Given this list of marker genes GPRC5B, OPA1, CDH16, GPR107, NLRP2, SLAMF8, BICD1, CTSW, F11R, MYL3, GOLM1, BTN3A1, DACH1, MAN1C1 (mannosidase alpha class 1C member 1), MYH6, ANGPTL7, TGFBR3, POLR1F, RORA, SLC2A6, GGPS1, BCL2L14, METTL3, PVT1, C2CD3, CHRNA2, ATP2A2, RIN3, VPS52, MTMR11, ASCL3, LTK, ACADSB (acyl-CoA dehydrogenase short/branched chain), SFTPB, LRRC37A3, PREX2, KDM4B, POLR3F (NCBI Gene Id 115527), VPS13B, PAK6, FSCN3, ZMYM6, PRND, SOX11, SLC7A1, ARHGEF15, HECTD3, PGBD5, PEPD, SSBP1, TNFAIP2, ADARB2 (NCBI Gene Id 55523), MET, MRPL34, EOGT, CDADC1, SLC17A4, PRRC2C, SMIM14, KLRC3, RNF220, APOC1, PLEKHA1, KTN1, RSAD1, LRIG2, CEACAM7, SLC7A2, OVGP1, SLC35D2, UMPS, NELL2, UTS2, NR3C2, ALOX15B, TARS2, ACSF2, GPR171, RANBP17, THSD7A, ZBTB44 (NCBI Gene Id 29068), DAZL, FHIT, MARCHF1, SLC35F6, EFR3B, KPTN, PSMC3IP, TPSG1, MOGAT2, NAB2, MYOM1, APOC2, CARF, GID4, AP3M2, GJC1, CCZ1B, LIG3 (DNA ligase 3), GFAP, GEM, CRHR2, PRKAA1, CYP21A2, SBNO1, SERPINA7, PAK3, SLIT2, IKZF3, KRT5, SETD6, FBXW11, SDR39U1, TSPYL2, WWC1, MARS1, ATP1B1, RAD17, KLHL35, HEATR6, LRRC37A4P, C3, CCDC92, FHL5, SLC35A2, ACSBG2, CYB5R3, ENSG00000274253, TPM3 (NCBI Gene Id 91191), HOXD11, MMS19, NSD3, NPY6R, PORCN, EMP1, CHRNA1, ABTB2, H4C9, BRWD1 (bromodomain and WD repeat domain containing 1), SPRR2B, DHRS3, AKR1C3, RTCA, BMERB1, STMN2, SPATA2, RAPGEFL1, FSTL1, BIN1, KRIT1, GADD45G, LY6G6D, NME5, BFSP2, MATCAP2, EXOSC2, PALM, EDA2R, KCNMB1, SIDT2, TASOR, CLIP3, OR6A2, TMEM39A, FCRL2, CKB (NCBI Gene Id 96634), GNG12, CHST3, LINC00342, RFX5, NEB, BAIAP3, PGF, ELF3, SLC49A3, NCAM2, CAT, GPR182, RER1, IL18, PCGF1, TAF5L, CLCA3P, ADAMDEC1, PHTF2, NFAT5, ABCF2, JPH3, PLAC1, TCP10L3, APOD, RAB3A, SYT2, IFT46, GSK3A, ZAP70, here is a description of the gene set: Genes up-regulated in HEK293 cells at 6h after stimulation by muramyl dipeptide: over-expressing mutant NOD2 versus control. Human Gene Set: GSE22611_MUTANT_NOD2_TRANSDUCED_VS_CTRL_HEK293T_STIMULATED_WITH_MDP_6H_UP from publication Billmann-Born S, Till A, Arlt A, Lipinski S, Sina C, Latiano A, Annese V, Häsler R, Kerick M, Manke T, Seegert D, Hanidu A, Schäfer H, van Heel D, Li J, Schreiber S, Rosenstiel P (PMID 21335489) NOD2 is an intracellular receptor for the bacterial cell wall component muramyl dipeptide (MDP) and variants of NOD2 are associated with chronic inflammatory diseases of barrier organs e.g. Crohn disease, asthma and atopic eczema. It is known that activation of NOD2 induces a variety of inflammatory and antibacterial factors. The exact transcriptomal signatures that define the cellular programs downstream of NOD2 activation and the influence of the Crohn-associated variant L1007fsinsC are yet to be defined. To describe the MDP-induced activation program, we analyzed the transcriptomal reactions of isogenic HEK293 cells expressing NOD2wt or NOD2L1007fsinsC to stimulation with MDP. Importantly, a clear loss-of-function could be observed in the cells carrying the Crohn-associated variant L1007fsinsC, while the NOD2wt cells showed differential regulation of growth factors, chemokines and several antagonists of NF-κB, e.g. TNFAIP3 (A20) and IER3. studied in species Homo sapiens